Given this list of marker genes STAT3, TMC8, SEC14L1, CAV1, YWHAG, TMSB4X, IMPACT, YWHAZ, LRRC15, CTNND1, SMAD6, FLNA, KIFBP, NCK1, SESN2 (NCBI Gene Id 83667), YWHAB, INSIG2, NORAD, TARBP2, MDFI, SRI, SDCBP, CDKN1A, SFN, NFKBIA, DBN1, YWHAE, LAPTM5, SPI1, DDX56, RBCK1, SMO, NFKBIE, INSIG1, SQSTM1, NFKB1, PMEPA1, CASTOR1, here is a description of the gene set: Human Gene Set: GOMF_PROTEIN_SEQUESTERING_ACTIVITY Binding to a protein to prevent it from interacting with other partners or to inhibit its localization to the area of the cell or complex where it is active. species: Homo sapiens